Given this list of marker genes RBPMS, ELAVL4, PRPF8 (pre-mRNA processing factor 8), RBM24 (NCBI Gene Id 221662), TARDBP, EP300, RNPC3, RBM7, HNRNPL, SOX9, RBM41, RBM20, RBM4, here is a description of the gene set: Binding to an intronic sequence of a pre-messenger RNA (pre-mRNA). species: Homo sapiens Human Gene Set: GOMF_PRE_MRNA_INTRONIC_BINDING